The following is a description of a gene set: Human Gene Set: GSE17186_NAIVE_VS_CD21LOW_TRANSITIONAL_BCELL_CORD_BLOOD_DN Goals/objectives: to identify various gene expression in B cell subsets derived from human PBMC and cord blood Genes down-regulated in B lymphocytes from cord blood: naïve versus transitional CR2. species: Homo sapiens from publication Suryani S, Fulcher DA, Santner-Nanan B, Nanan R, Wong M, Shaw PJ, Gibson J, Williams A, Tangye SG (PMID 19965666), and this is the list of marker genes: TPM2, COPG2, CACNA1S, PTP4A2, AMZ1, TEX15, S100A6, CEP55, GCNT1, FAR1, SWAP70, TMEM123, CORO2A, STARD3NL, SLC25A11, EPN1, WDR5B, DPP4, AURKB, SKIC3, PLD2, RBPJ, H1-0, LTBR, NELFE, ATAD5, PTPRS, SLC44A1, TJP2, IFNGR2, NOXRED1, DEPDC7, TRIQK, CHKA, ITGAM, GPR137B, CD300LB, APAF1 (apoptotic peptidase activating factor 1), POGLUT2, INCENP, ZNF600, CDC20, CEP290, ARHGAP42, GPR155, LSP1, TRIP13, FAM43A, TGFBR1, NRROS, SERPINB2, TUSC1, ARHGEF6, SPAG9 (NCBI Gene Id 9043), S100PBP, IFT140, SRRM1, B9D2, NEURL2, H2AZ1, TUBB6, ALDH16A1 (aldehyde dehydrogenase 16 family member A1), AIM2 (NCBI Gene Id 9447), HPS3, UCP2, CCDC34, PTMS, LEPROT, EVI5, DSCAM, NLRP10, CDYL2, GTF2A1, FGD2, FNIP1, TMEM170B, RRAS (NCBI Gene Id 6237), CD80, PTPRE, MFAP3, SYPL1, PRKAR2A, GATM, YWHAG, ENO3, CCNA2, TYMS, TSPAN31, ABHD6, EEPD1, RCAN1, ACE, SREBF2, SFMBT1, NMRAL1, TMEM131L, SH3BGRL, LPIN2, SMIM3, SESN2 (sestrin 2), EIF4ENIF1, PRKCB, MALT1, KIF20A, PUS10, TRAF1, SEPTIN10, KPTN, ZNF367, TLR1, SPINT1, ZNF263, TREX1, PEX16, OMA1, APIP, NOD1, FCGR3A, CLPTM1, MTMR4, DIPK1A, AKT1, PLSCR1, LPAR3, ITGB2, NCAPD2, TTC8, PTPN3, SLC2A6, EHD4, KDM2B, FSCN1, QKI, SLC25A35, GOLGA7, STAG3, TMPO, TMEM35B, PAOX, PLS3, CEBPD, ARAP2, PLK1, CDC6 (cell division cycle 6), SLC66A3, RAB14, LMTK2, BUB1B, FIGNL1, ESPL1, ACP2, RAB31, BIRC5, GCA, DHRS13, RNF216, CBX5, SPECC1, ITGB1, MAD2L1, UBE2G2, CTC1, ABHD1, ANKH, LTA4H, LRP1, KCNIP3, CXCL9, PRRC1, RPS6KA4, AURKA, IQGAP3, INPPL1, SAMHD1, SULF2, HLX, CRISPLD2, CENPF, AKT3 (NCBI Gene Id 26068), E2F3, ST3GAL5, MICU1, METRNL, PMF1, HSD17B4, RPS6KA5, TTK, ACTG1 (actin gamma 1), RAD51, CADM3, ABCB1, TNS1, CORO1B, GNG10, CASP7, SNX30, FBXW12, BIRC3, RAPGEF1, KRT80